Given this list of marker genes LONP1, PDHA1, ATP1A2, SCN1A, ALDH7A1, CACNA1A, PRRT2, PLPBP, ALDH4A1, PIGT, here is a description of the gene set: EEG with generalized sharp slow waves studied in species Homo sapiens EEG with generalized sharp transient waves of a duration between 80 and 200 msec followed by a slow wave. Human Gene Set: HP_EEG_WITH_GENERALIZED_SHARP_SLOW_WAVES